Given this list of marker genes Mterf2 (mitochondrial transcription termination factor 2), Thap11, Tfb1m, Mterf1a, Tfb2m, Prkaa1, Foxo3, Polr1a, Mterf4, Kansl1 (NCBI Gene Id 76719), Ppargc1b, Mrpl12, Tfam, Mettl4, Twnk, Polrmt, Mterf3 (mitochondrial transcription termination factor 3), Mtres1, Kat8, Sirt3 (sirtuin 3), Polr3b, Mterf1b, Polr2a, Tefm, Polr1b (polymerase (RNA) I polypeptide B), Polr2b, Slc25a33, Kansl3, here is a description of the gene set: Mouse Gene Set: GOBP_MITOCHONDRIAL_TRANSCRIPTION The synthesis of RNA from a mitochondrial DNA template, usually by a specific mitochondrial RNA polymerase. studied in species Mus musculus